Given this list of marker genes Slc22a14, Slc52a3 (solute carrier protein family 52, member 3), Abcg2, Slc52a2, Abcg3, here is a description of the gene set: studied in species Mus musculus Mouse Gene Set: GOBP_RIBOFLAVIN_TRANSPORT The directed movement of riboflavin into, out of or within a cell, or between cells, by means of some agent such as a transporter or pore. Riboflavin (vitamin B2) is a water-soluble B-complex vitamin, converted in the cell to FMN and FAD, cofactors required for the function of flavoproteins.